Given this list of marker genes Nrg3, Egf, Hbegf (NCBI Gene Id 225370), Pik3r1, Btc, Pik3ca, Gab1, Erbb4 (NCBI Gene Id 13869), Erbb2, Ereg, Nrg1, Egfr, Grb2, Erbb3, here is a description of the gene set: Mouse Gene Set: REACTOME_PI3K_EVENTS_IN_ERBB2_SIGNALING studied in species Mus musculus PI3K events in ERBB2 signaling